The following is a description of a gene set: Polycystic kidney dysplasia Human Gene Set: HP_POLYCYSTIC_KIDNEY_DYSPLASIA The presence of multiple cysts in both kidneys. species: Homo sapiens, and this is the list of marker genes: TSC1, ARVCF, OFD1, DNAJB11, PEX5, TMEM231, SKIC3, SKIC2, PKHD1, CDC73, PKD2, TCTN2, SRCAP, ALG9, PEX12, ETFDH, DZIP1L (NCBI Gene Id 199221), RREB1, IFT43, GATA3, GLIS3, TSC2, GANAB, ESCO2, PEX2, NEK1, ANKS6, JMJD1C, KIAA0586, MKKS, SIX1, ETFB, RNU4ATAC, SEC24C, MKS1, WDR35, COMT, TRIP11, IFNG, PKD1, UFD1, CPT2, EYA1 (EYA transcriptional coactivator and phosphatase 1), TMEM218, ZNF423, DYNC2H1, NPHP3, TBX1, ETFA, TMEM107, NAA10, SHANK3, HIRA, NOTCH2, TXNDC15, GP1BB